The following is a description of a gene set: Human Gene Set: GR_Q6 Genes having at least one occurrence of the motif NNNNNNCNNTNTGTNCTNN in the regions spanning 4 kb centered on their transcription starting sites. This matches the NR3C1 transcription factor binding site V$GR_Q6 (v7.4 TRANSFAC). species: Homo sapiens, and this is the list of marker genes: DLG2, MYH4, DTX2, LHX6, ANTXR1, AFF3 (ALF transcription elongation factor 3), RIMS2, WDR81, PTMS, GRP, FOXP4 (forkhead box P4), ELAVL2 (NCBI Gene Id 1993), B4GALT5, EYA1, PI4KB, LUC7L3, QRICH1, MOSPD2, GBE1 (NCBI Gene Id 2632), TAAR2, KCNA5, GDNF, GLRA2, ASXL2, PCDH8, RRAGD, RCN1, NR2F1, SH2D1A, ACKR1, ABCD2, CCDC126, WFIKKN2 (NCBI Gene Id 124857), FGF13, ZNF205, LRRFIP1, KCNV1, PDE6D, ARFIP2 (NCBI Gene Id 23647), PAK1IP1, ASF1A, PSEN1, HAUS3, RTL3, VCPKMT, MBOAT2, NEUROD4, ONECUT2, MARCKSL1 (NCBI Gene Id 65108), JPH1, RBM3, B3GALT2, PMCHL2, CBLN4, C1orf43, SIX1, INSM1, FANCB, PLAGL1, SLC32A1, PMCHL1, KCND2, HOXD10, PKP4, HOXA11, COLQ, RANBP9, SLC18A3, HNMT, GPHA2, HAPLN1, GFOD1, ACVR2A, DLX1, CEACAM4, ZEB2, SCHIP1, BCLAF3, UBR2, HOXB7, CHAT, PRDX2 (NCBI Gene Id 7001), CHST9 (NCBI Gene Id 83539), MPZ, GPBP1, UBE2Z, RELCH, LGI3, CALCR, ONECUT1, ICMT-DT, MID1, ELAVL4, KRT10, RAB1B, CNTN4, FGF17, PRKAG1, TYRO3, MAP3K19, VASN, LRRTM3, TIMM8A, CDK2AP1, ADIG, RBMS1, RIPOR1, DAAM2, LARP4, ARHGEF19, PRX, MITF, RBM24, CRHR2 (NCBI Gene Id 1395), NLRP10, KLHL7, GOT2, SETBP1, ADAMTSL1, CLC, LYSMD2, ZP3, PAX7, RESF1, BRINP3 (BMP/retinoic acid inducible neural specific 3), SPEM1, FBXW7, PCDH18, CD109, NOTCH4, ADORA1, LIFR, GOLGA2P11 (NCBI Gene Id 255180), RAPGEFL1, AGAP3, CA14, MIR22HG, TEAD1, RCOR2, WNT4, SLC9A9, TFAP2D, ADNP, NDST4, CXCL14, CRCT1, SLC38A2, LURAP1L, MBNL1, TAS2R60, PDE2A, SUN2 (NCBI Gene Id 25777), LINC00114, NDST2, PABPC4, FLRT3, SREK1, TXNIP, MCM7, NEGR1, SRGN, TSC22D3, ZNF771, TNNI1, RGS3, LRR1, FES, NKX2-8, LRCH2, NNAT, WT1-AS, FGD4, FGF9, GYS1, CLEC1A, PPM1A, LMO3, MOAP1, PPP2R2B, MMP7, ADGRB3, SDC1, LAMB1, SPATA31G1, ZNF654, SRPK2, MEIS2, RARA, GCNT3, TSSK3, USP2, RUVBL2, MIA, PTPDC1, GPRC6A, IP6K2, SGK2, FBXW4, KLF5, PRKCG, PLAG1, ASB2, PAX2, IKZF2, PGGT1B, WASF2, RBM23, JPH2, SYNCRIP, ZMYND8, ESR1, FGF12, GREB1, HMGB1 (high mobility group box 1), SHOX2, HOXA2, TRIP11, TRAF6, WWP2, BNC2, ZNF532, ZNF385B, USP54 (NCBI Gene Id 159195), DLG5, PRRX1 (NCBI Gene Id 5396), LINC00670, TMOD3, CDKN1A, LARGE1, TNMD, YARS1, MBP, SNORC, RTL10, ZNF423, BTK, PRG4, H3-3B (NCBI Gene Id 3021), TMEM101, DRG2, HMGN5, RAB3C, SCARB2, LOX, STK3 (NCBI Gene Id 6788), CHRM1, DAW1, ENOX2, ZBTB32 (NCBI Gene Id 27033), KLF8 (KLF transcription factor 8), DEFB119, NCAM1, PARP8, NOG, NR1H4, LINC01565, GNB1L, VAX1 (NCBI Gene Id 196056), RERE, ADCY6, AUTS2, RAB30, RNF38, R3HDM2, TEF, DCHS2, BHLHE40, AP4M1, DLX3, NT5C3A, CTNND2, NCDN, GIPC2, ATP5MC3, TGIF1